Given this list of marker genes SLC35D2, B3GNT3, PRELP, AGRN, EXTL3, HAS1, GPC1, CHST11, SLC26A2, HPSE2, ARSB, SDC2, XYLT2, GPC6, GPC2, B3GNT2, CSGALNACT1, HYAL4, GPC5, B4GALT1, SLC26A1, PAPSS2, PXYLP1, IDUA, HS3ST4, GNS, NDST3, B4GALT5, HS3ST2 (heparan sulfate-glucosamine 3-sulfotransferase 2), ST3GAL2, ST3GAL1 (NCBI Gene Id 6482), CHSY1, B4GALT4, SLC35B2, EXTL2, HS3ST1, HS6ST1, HYAL1, HEXA, B3GNT4, ST3GAL6, GUSB, GALNS, HAS3, CHP1, FAM20B, OMD, CHST13, GLB1L3, SPAM1, CD44, B4GALT3, B4GAT1 (beta-1,4-glucuronyltransferase 1), SLC17A5, BCAN, GLB1 (NCBI Gene Id 2720), ABCC5, GLCE, B3GALT6, CSPG5, HS3ST5, CEMIP, SDC4, ACAN, CHPF (NCBI Gene Id 79586), B4GALT6, CHST7, CHST14, VCAN, NDST2, EXT2, UXS1, OGN, STAB2, FMOD, HPSE, CHST3, B3GNT7 (NCBI Gene Id 93010), CTSL, B3GAT3, SDC1, LYVE1, HYAL2, HS6ST2, SGSH, LUM (NCBI Gene Id 4060), CHSY3, B3GAT2, CHST1, B4GALT7, B3GAT1, CHST12, ST3GAL4, GPC4, EXT1, DSEL, DCN, CHST9, NDST4, BGN, UST, GPC3, ST3GAL3, KERA, GLB1L2, HMMR, CHPF2, NCAN, PAPSS1, CHST2, CHST15, CSGALNACT2 (NCBI Gene Id 55454), HS3ST6, SDC3, GLB1L, HSPG2, HS3ST3A1, DSE, HAS2, IDS, B4GALT2, XYLT1, CHST6, HEXB, HS3ST3B1, HYAL3, HS6ST3, NDST1, HGSNAT, HS2ST1, CSPG4, NAGLU, SLC35B3, SLC9A1, CHST5, SLC26A11, here is a description of the gene set: Glycosaminoglycans (GAGs) are long, unbranched polysaccharides containing a repeating disaccharide unit composed of a hexosamine (either N-acetylgalactosamine (GalNAc) or N-acetylglucosamine (GlcNAc)) and a uronic acid (glucuronate or iduronate). They can be heavily sulfated. All GAGs (except hyaluronan) are bound to proteoglycans (PG) via the tetrasaccharide linker -GlcA-Gal-Gal-Xyl- on O-serine residues of the core protein. Hyaluronan and GAG-PGs are located primarily in the extracellular matrix (ECM) and on cell membranes, acting as a lubricating fluid for joints and as part of signalling processes. They have structural roles in connective tissue, cartilage, bone and blood vessels. GAG-PGs are degraded in the lysosome as part of their natural turnover. Defects in the lysosomal enzymes responsible for the metabolism of membrane-associated GAG-PGs lead to lysosomal storage diseases called mucopolysaccharidoses (MPS). MPSs are characterised by the accumulation of GAGs in lysosomes resulting in chronic, progressively debilitating disorders that in many instances lead to severe psychomotor retardation and premature death (Cantz & Gehler 1976, Clarke 2008).It is unclear but probable that GAG chains are cleaved off PGs, leaving the tetrasaccharide linker on the protein, which then is degraded by β-glucuronidase, two β-galactosidases, and a β-xylosidase. The biosynthesis and breakdown of the main GAG chains (hyaluronate, keratan sulfate, chondroitin sulfate, dermatan sulfate and heparan sulfate) is described here. Reactome Pathway: Glycosaminoglycan metabolism studied in species Homo sapiens part of: Metabolism of carbohydrates and carbohydrate derivatives